The following is a description of a gene set: Human Gene Set: GOBP_SNORNA_LOCALIZATION studied in species Homo sapiens Any process in which small nucleolar RNA is transported to, or maintained in, a specific location., and this is the list of marker genes: NOP58, ZNHIT6 (NCBI Gene Id 54680), ZNHIT3, FBL, PRPF31, PIH1D1